The following is a description of a gene set: Human Gene Set: HUI_MAPK14_TARGETS_UP from publication Hui L, Bakiri L, Mairhorfer A, Schweifer N, Haslinger C, Kenner L, Komnenovic V, Scheuch H, Beug H, Wagner EF (PMID 17468757) Genes up-regulated in fetal liver (days E13.5 and E15.5) samples from embryo-specific Cre-lox knockout of MAPK14. species: Mus musculus The mitogen-activated protein kinase (MAPK) p38alpha controls inflammatory responses and cell proliferation. Using mice carrying conditional Mapk14 (also known as p38alpha) alleles, we investigated its function in postnatal development and tumorigenesis. When we specifically deleted Mapk14 in the mouse embryo, fetuses developed to term but died shortly after birth, probably owing to lung dysfunction. Fetal hematopoietic cells and embryonic fibroblasts deficient in p38alpha showed increased proliferation resulting from sustained activation of the c-Jun N-terminal kinase (JNK)-c-Jun pathway. Notably, in chemical-induced liver cancer development, mice with liver-specific deletion of Mapk14 showed enhanced hepatocyte proliferation and tumor development that correlated with upregulation of the JNK-c-Jun pathway. Furthermore, inactivation of JNK or c-Jun suppressed the increased proliferation of Mapk14-deficient hepatocytes and tumor cells. These results demonstrate a new mechanism whereby p38alpha negatively regulates cell proliferation by antagonizing the JNK-c-Jun pathway in multiple cell types and in liver cancer development., and this is the list of marker genes: ASB1, CNTNAP2, GADD45G, C1QTNF4, PKHD1L1, MAP2K6, PRNP, GRAP2, JUN, ITGB7, LRRC39, PAK6, ISG15, JUND, GADD45A, SFRP1, FHL1, DUSP8, SLC23A1, TRGV11